The following is a description of a gene set: Human Gene Set: FISCHER_BLOOD_PLASMA_RVSV_EBOV_AGE_18_55YO_HIGH_DOSE_3DY_DN VSV-EBOV is a replication-competent Ebola virus (EBOV) vaccine, which was tested in clinical trials as response to the Ebola virus disease (EVD) outbreak 2013-2016. It is the most advanced EBOV candidate currently in the licensure process. The experimental vaccine was again administered as response to outbreaks in the Democratic Republic of Congo. However, underlying molecular mechanisms that convey protection remain incompletely understood. MicroRNAs (miRNAs) are known key regulators that influence gene expression on a post-transcriptional level. The miRNA-mediated control has emerged as a critical regulatory principle in the immune system, which strongly influences the balance of innate and adaptive immune responses by modulation of signaling pathways critical for differentiation of immune cells. We investigated expression levels of circulating miRNAs (c-miRNAs) in plasma from healthy vaccinees, as they may reflect cellular dynamics following VSV-EBOV immunization and additionally may serve as potential biomarkers for vaccine efficacy. As part of the WHO-led VEBCON consortium, we investigated safety and immunogenicity of VSV-EBOV in a phase I trial. A comprehensive analysis of expression levels on c-miRNAs from plasma samples following VSV-EBOV immunization (day 0, 1, 3 post vaccination) was conducted using RT-qPCR assays. Potential biological relevance was assessed using in silico analyses. Additionally, we correlated dynamics of miRNA expressions with our previously reported data on vaccine-induced antibody and cytokine responses and finally evaluated the prognostic power by generating ROC curves. We identified four promising miRNAs (hsa-miR-146a, hsa-miR-126, hsa-miR-199a, hsa-miR-484), showing a strong association with adaptive immune responses, exhibited favourable prognostic performance and are implicated in immunology-related functions. Our results provide evidence that miRNAs may serve as useful biomarkers for prediction of vaccine-induced immunogenicity. Furthermore, our unique data set provides insight into molecular mechanisms that underlie VSV-EBOV-mediated protective immune responses, which may help to decipher VSV-EBOV immune signature and accelerate strategic vaccine design or personalized approaches. from publication Fischer T, Spohn M, Olearo F, Zinser ME, Kasonta R, Stubbe HC, Rechtien A, Ly ML, Schmiedel S, Lohse AW, Grundhoff A, VEBCON (VSV-Ebola Consortium), Addo MM, Dahlke C (PMID 30244872) studied in species Homo sapiens Genes down-regulated in blood plasma 3d vs 0d in adults (18-55) (high dose) after exposure to rVSV-EBOV, time point 3D, and this is the list of marker genes: MIR23A, MIR126, MIR24-1, MIR199A2, MIR221, MIR30D